Given this list of marker genes Adipoq (adiponectin, C1Q and collagen domain containing), Nod2, Twist1, Cd84, Oas1h, Clec7a, Oas1c, Mcoln2 (mucolipin 2), Oas3, Oas1b, Oas1g (2'-5' oligoadenylate synthetase 1G), Il1b, Trpv4, Oas1d, Hmgb1, Oas1a (2'-5' oligoadenylate synthetase 1A), Oas1f, Oas1e, Selenok, Syk, Ager, here is a description of the gene set: Any process that activates or increases the frequency, rate, or extent of production of monocyte chemotactic protein-1. studied in species Mus musculus Mouse Gene Set: GOBP_POSITIVE_REGULATION_OF_MONOCYTE_CHEMOTACTIC_PROTEIN_1_PRODUCTION